Given this list of marker genes PTCH1, IHH (NCBI Gene Id 50819), GAS8 (growth arrest specific 8), EVC, EVC2, SMO, DHH, SHH (NCBI Gene Id 6469), KIF3A, BOC, GRK2, EFCAB7, CSNK1A1, GAS1, IQCE, ARRB2, ARRB1, CDON, here is a description of the gene set: Activation of SMO Human Gene Set: REACTOME_ACTIVATION_OF_SMO studied in species Homo sapiens